The following is a description of a gene set: Cluster 0: genes changed in primary keratinocytes by UVB irradiation. species: Homo sapiens Human Gene Set: SESTO_RESPONSE_TO_UV_C0 UV radiation is the most important environmental skin aggressor, causing cancer and other problems. This paper reports the use of oligonucleotide microarray technology to determine changes in gene expression in human keratinocytes after UVB treatment. Examination of the effects of different doses at different times after irradiation gave a global picture of the keratinocyte response to this type of insult. Five hundred thirty-nine regulated transcripts were found and organized into nine different clusters depending on behavior patterns. Classification of these genes into 23 functional categories revealed that several biological processes are globally affected by UVB. In addition to confirming a majority up-regulation of the transcripts related to the UV-specific inflammatory and stress responses, significant increases were seen in the expression of genes involved in basal transcription, splicing, and translation as well as in the proteasome-mediated degradation category. On the other hand, those transcripts belonging to the metabolism and adhesion categories were strongly downregulated. These results demonstrate the complexity of the transcriptional profile of the UVB response, describe several cellular processes previously not known to be affected by UV irradiation, and serve as a basis for the global characterization of UV-regulated genes and pathways. from publication Sesto A, Navarro M, Burslem F, Jorcano JL (PMID 11867738), and this is the list of marker genes: YWHAH, TPMT, SAP18 (NCBI Gene Id 10284), CXCL1, SET, KPNA2, GTF2B, LSR, PSMA4, SSX2 (SSX family member 2), TAF9, HCCS, GDF15, HMOX1, TRAF4, SPRR2C, M6PR, TACSTD2, UBE2V2, RIT1, XPC, BAMBI, CITED2 (NCBI Gene Id 154106), KPNA4, DNTTIP2, TRIM26, GSK3A, DSC2, PPP2CB, HSPH1, RAB21, DAZAP2, CDC37, NDUFA4, PKP1, NEU1, COPS2, CTR9, PPIF, PSG7, POLR2A, ELOC, TCP1, SP3, CHMP1A, GTF2A2, WTAP, MCFD2, USP10, BPGM (bisphosphoglycerate mutase), EIF2B1, TRAF6, DHX38, DR1, HSPA1A (NCBI Gene Id 3303), PSMD6, PCNA, MRPL49, TFPI2 (tissue factor pathway inhibitor 2), CDK7, TAF7, TFRC (NCBI Gene Id 7037), ARL6IP1, TAP1, SAA1, GNAI1, SLC39A6, CLTA, BRD2, DNAJA1, ERBB3, SERPINB4, RNF113A, ZFP36, ADM, PNP, IL1R2, PTP4A1, EIF4A3, ANXA1, H3-3A, HARS1, CLP1, RPS27, PSMA3, BAG1, EIF4G2, QSOX1, NFKBIA, RRAGA, POLR2K, ISCU, CNBP, TRAM1, CAMLG (calcium modulating ligand), NCBP2, IL1RN, RBM4, SQSTM1, PRNP, EIF2S1, HNRNPH2, DYNLL1, PRSS8, PPP1CC, SON, PGRMC1, EIF5 (eukaryotic translation initiation factor 5), TUBA1A